Given this list of marker genes Tafazzin, Pla2g4a, Hadhb, Hadha, Lclat1, here is a description of the gene set: species: Mus musculus Mouse Gene Set: REACTOME_ACYL_CHAIN_REMODELING_OF_CL Acyl chain remodeling of CL